Given this list of marker genes FARS2, EDC3, CLASP1, ZNF415, ACSL4, ZBED6, XRCC2, ZNF573, TOPBP1, CLIC3, DIPK1A, CDK19, MTERF1, ENTREP3, BTBD8, ATAD2B, ATG7, RBIS, THOC6, TSPYL4, PLOD3, MDN1, RAB12, BRMS1L, LINC00649, TMED8, RGS16, ZNF248, SLC35D1, SH2B1 (SH2B adaptor protein 1), THAP2, RHBDD3, VPS35L, ZNF391, NMU, SLC2A11, MATN2, CELSR2, DELE1, COG7, RP9, MLYCD, COQ8B, FNDC3B, POLR3C, ATRIP, CSKMT, UBE2O, SLFN13, ATP9B, MLKL, PSTK, NUSAP1, ARMC5 (NCBI Gene Id 79798), SPTLC3, AGPAT4, ZNF44, FMO4, PTPRE, CEP152, PHOSPHO2, PDGFD, CAVIN3, CCDC144A, ZDHHC1, CFAP96, NXPE3, FAM13A-AS1, MRRF, INTS1, TRMT1, SNIP1, ATP5MG, KLHL29, C6orf136 (chromosome 6 open reading frame 136), ATP5MC3 (ATP synthase membrane subunit c locus 3), RAD17, PCTP (phosphatidylcholine transfer protein), STARD4-AS1, FAM13A (NCBI Gene Id 389211), ZNF92, IDUA, TAPT1-AS1, MED25, SLC12A9, PCGF1, CEBPZOS, CEP72, MCOLN2, ZFP14, ZFP30, TTL, ZC3H11A, ITPK1, ANKS3, DNAAF9, QRICH1, KIF11, SMYD3, ABHD16A, CENPF, APLF, POLR1HASP (POLR1H antisense, pseudogene), VRK1, MAPKBP1, SRD5A3, FBXL4, CCZ1B, LRRC75A, AMDHD2 (amidohydrolase domain containing 2), ASPM, LDB1, DTYMK, ZNF626, RAB3IP, ZNF236 (zinc finger protein 236), ZNF827 (zinc finger protein 827), CASP2, CIDEB, ZC3H7B, RIN1, EEFSEC, GPATCH2, SLC49A4, NAPEPLD, AUTS2, EIF2B1, ZNF621, PELP1, SUGP1, OXSM, LONRF1, DMAC2, EHHADH, PIP5K1C, NF2, LINC00663, TECPR1, HAUS4, TM4SF4, ADH7, DNAJC27, BAG4, FDXACB1, ANKRD54, NKAIN4, FABP6, SLF2, here is a description of the gene set: from publication Gautam P, Hamashima K, Chen Y, Zeng Y, Makovoz B, Parikh BH, Lee HY, Lau KA, Su X, Wong RCB, Chan WK, Li H, Blenkinsop TA, Loh YH (PMID 34584087) studied in species Homo sapiens Occular cell types curated from Gautam and Hamashima et al. Multi-species single-cell transcriptomic analysis of ocular compartment regulons Human Gene Set: GAUTAM_EYE_CORNEA_CYTOTOXIC_T_CELLS